The following is a description of a gene set: Human Gene Set: CORRE_MULTIPLE_MYELOMA_DN Recent literature suggested that cells of the microenvironment of tumors could be abnormal as well. To address this hypothesis in multiple myeloma (MM), we studied bone marrow mesenchymal stem cells (BMMSCs), the only long-lived cells of the bone marrow microenvironment, by gene expression profiling and phenotypic and functional studies in three groups of individuals: patients with MM, patients with monoclonal gamopathy of undefined significance (MGUS) and healthy age-matched subjects. Gene expression profile independently classified the BMMSCs of these individuals in a normal and in an MM group. MGUS BMMSCs were interspersed between these two groups. Among the 145 distinct genes differentially expressed in MM and normal BMMSCs, 46% may account for a tumor-microenvironment cross-talk. Known soluble factors implicated in MM pathophysiologic features (i.e. IL (interleukin)-6, DKK1) were revealed and new ones were found which are involved in angiogenesis, osteogenic differentiation or tumor growth. In particular, GDF15 was found to induce dose-dependent growth of MOLP-6, a stromal cell-dependent myeloma cell line. Functionally, MM BMMSCs induced an overgrowth of MOLP-6, and their capacity to differentiate into an osteoblastic lineage was impaired. Thus, MM BMMSCs are abnormal and could create a very efficient niche to support the survival and proliferation of the myeloma cells. Genes down-regulated in multiple myeloma (MM) bone marrow mesenchymal stem cells. studied in species Homo sapiens from publication Corre J, Mahtouk K, Attal M, Gadelorge M, Huynh A, Fleury-Cappellesso S, Danho C, Laharrague P, Klein B, Rème T, Bourin P (PMID 17344918), and this is the list of marker genes: IMPA2, HOXA10, TNFRSF19, GAS1, LAMA2, TMEM119 (transmembrane protein 119), OLFML3, EZR, TRIM59, PRRT2, KIF21A, FNDC1-AS1 (FNDC1 antisense RNA 1), IGF1, TENT5B, TCEA3, COLEC12, CNKSR3 (CNKSR family member 3), SULF2, PENK, CCN4, CH25H, FZD1, HS3ST3B1, POTEKP, ZFP36L2, SETBP1, NEK2, LIN7A, LINC00840, BARD1, FOS (NCBI Gene Id 2353), PLCL1, NLGN4X, LRIG3, EYA2, LPAR1, PTGR3, MAMDC2, FBLN1, INSIG1, NPR3, CXCL12, RPL39L, SPATA1, RBP4, HOXA9, BLVRA, MEOX2, ACAN, COL11A1, ALDH7A1, LAPTM5, CDCA5, MME, FBXO6, CADPS2, SLC1A3, SELENBP1, MAF